The following is a description of a gene set: species: Homo sapiens Human Gene Set: GOBP_GLYCOSPHINGOLIPID_METABOLIC_PROCESS The chemical reactions and pathways involving glycosphingolipids, any compound with residues of sphingoid and at least one monosaccharide., and this is the list of marker genes: MIR195, TM9SF2, CLN6, SUMF1, GLA, ST6GALNAC5, ST6GALNAC4, B3GALT2, ST3GAL1, A3GALT2, B3GALNT1, LCT, UGT8, ST6GALNAC3, HEXB, ST8SIA6, GAL3ST1, ENPP7, ST3GAL5, M6PR, NEU1, MIR16-1, SMPD1, ST6GALNAC6, KIT, B3GNT5, ABCA2, SCARB2, ITGB8, CERK, ST8SIA2 (NCBI Gene Id 8128), NEU3, UGCG, B4GALT4 (NCBI Gene Id 8702), ST8SIA1, ST8SIA3, GALC, FUT2, GM2A, PRKAA1, A4GALT, C20orf173, ST8SIA5, GBA3, PRKCD, GBA1 (NCBI Gene Id 82008), CREM, B4GALT3, NAGLU, ST3GAL3, FUT4, MIR127, GLB1, FUT1 (fucosyltransferase 1 (H blood group)), B4GALNT1, HEXA, FUT9, GBA2, ST8SIA4, B4GALT5, FUT6, LARGE1, FA2H, B4GALT6, ST3GAL2, BAX, NEU4, B3GALT1, NEU2, B3GALT4